Given this list of marker genes Fcnb, Xrcc6, Gps2, Mfhas1, Havcr2, Trim12c, Peli1, Inava, Scimp, Nek7, Casp4, Phb2, Rnf135, Arf6, Tril, Plcg2, Peli3, Zdhhc5, Dab2ip, Klri2, Irgm1, Tifab, Pik3r1, Trim30d, Klrd1, Ifi208, Sfpq, Trim32, Oas1e, Matr3, Tnfaip3 (NCBI Gene Id 21929), Letmd1, Mbl2 (NCBI Gene Id 17195), Ikbke, Nlrp1a, Traf6, Sting1, Tlr4, Tlr11, Bcl10, Hcfc2, Cav1, Sin3a, Prkd1 (NCBI Gene Id 18760), Slc19a1, Rps6ka3, Ninj1, Ifi35, Zcchc3, Pik3ap1, Otud4, Bpifb1, Lrch4, Appl2, Stmp1, Klrk1, Lyplal1, Cptp, Tlr6, Fcna, Irgm2, Dhx58, Nr1h4, Oas3, Klrc3, Lats1, Cgas (cyclic GMP-AMP synthase), Tnip1, Fosl1, Itch, Reg3g, Pum2, Gm12250, Cd36, Ifi207, Tnf, Trim30a, Ufd1, Oas1c, App, Map3k7, Fbxl2, Src, Ogt, Oas1h (2'-5' oligoadenylate synthetase 1H), Tlr12, Nr1h3, Treml4, Mark4 (MAP/microtubule affinity regulating kinase 4), Ripk2, Nono, Brcc3, Ticam1, Nlrc3 (NCBI Gene Id 268857), Nlrc4, Oas1g, Cyba, Ifi206, D1Pas1, Kcnk13, Sqstm1, Smpdl3b, Tasl, Gm15441, Smpdl3a, Aars2, Ticam2, Oas1d, Ppp2ca, Ppt1, Igtp, Unc93b1 (NCBI Gene Id 54445), Trim30b, Parp1, Nr1d1, Naglu, Hmgb1, Syk, Flot1, Rnf170, Ifi203-ps (interferon activated gene 203, pseudogene), Gbp3, Atat1, Ppp6c, Xiap, Tspan6, Zbp1, Lbp, Ddx3x, Nfkbiz, Ifi203, Hexim1, Clpb, Elp6, Trem2, Nploc4, Casp6, Banf1, Gbp2, Mapkapk2, Lrrc14, Tyrobp, Tlr7, Prkce, Traf3ip3, Rnf34, Rnf115, Ptprs, Nod1, Tifa, Cactin, Zc3hav1, Cd300a, Cd86, Zdhhc12, Klri1, Lamp2, Tlr1, Zdhhc9, Chuk, Ifi204, P2rx7, Aurkb, Oas1b, Ddx60, Appl1, S100a14, Irak3, Brcc3dc, Pdpk1, Klre1, Rab11fip2, Trim30c, Abhd17a, Rab7b, Eif2ak2, Rtn4, Tlr5, Csnk1a1 (casein kinase 1, alpha 1), Rsad2, Tlr13, Hspa1b (NCBI Gene Id 15511), Rnf144a, Rftn1, Ccdc134, Trim11 (NCBI Gene Id 94091), Phb1, Trim5, Sarm1, Irf4, Oasl1, Tirap, Traf3, Riok3, Ffar2, Mavs, Tnip2 (NCBI Gene Id 69105), Cd300lf, Trim25, Washc4, S100a9, Btk, Irf7, Gbp7, Epg5, Lacc1, Ltf, Nmi, Pspc1, Ifi205, Ifi213, Ywhae, Klrc1, Oas1f, Pja2, Nfkbil1, Klrc2 (NCBI Gene Id 16642), Rela, Wdfy1, Tlr2, Lgr4, Lrrc19, Znrf1, Zdhhc3, Slc15a2 (NCBI Gene Id 98014), Tab1, Trim3 (NCBI Gene Id 55992), Rigi, Tyro3, Usp50, Aim2, Hspd1, Ifi211, Tlr8, Irf1, Ly96, Znrf4, Kcnj8, Tmem126a, Xrcc5, Ptgs2os, Gpr108, Irak1, Otulin, Lats2, Cd274, Zdhhc18, Irf3, Ipo5, Hspa8, Pum1, Rnf125, Ecsit, Slc46a2 (NCBI Gene Id 80480), C1qbp, Gfi1, Clec4e, Nod2, Zdhhc1, Pcbp2, Mapk8, S100a8, Tax1bp1, Sirt2, Irf2, Colec12, Ankrd17, Trim15, Arrb2, Ubqln1, Ifi214, Lrrfip2, Nfkbia, Pycard, Becn1, Cd14, Sec14l1, Esr1, Nlrp3, Slc15a3, Trim12a, Tlr3, Nagk, Lsm14a, Gkn2, Gbp2b, Nlrp10, Lyn, Acod1, Prkdc, Oas1a, Irak2, Tarbp2, Myd88, Znfx1, Tkfc, Pqbp1, Gbp5, Nlrp1b, Gdi1, Tbk1, Tomm70a, Alpk1, Ifi209, Tnip3, Clec7a, Ap3b1, Mefv, Dhx33, Spsb3, Mndal, Rbm14, Mapkapk3, Cd300ld3, Hsp90aa1, Nop53, Tlr9 (NCBI Gene Id 81897), Trim31, Nlrx1, Gramd4, Casp1, Akt1, Usp15, Usp17le, Nlrp6, Slc15a4, Gpatch3, Ifih1, Ptpn22, Clec4n, Erbin, F2rl1, Trex1, here is a description of the gene set: Mouse Gene Set: GOBP_ACTIVATION_OF_INNATE_IMMUNE_RESPONSE Any process that initiates an innate immune response. Innate immune responses are defense responses mediated by germline encoded components that directly recognize components of potential pathogens. Examples of this process include activation of the hypersensitive response of Arabidopsis thaliana and activation of any NOD or TLR signaling pathway in vertebrate species. studied in species Mus musculus